Given this list of marker genes RAD51, POMT1, TCTN1, STAG1, CDC42, KIF7, SETBP1, SOX11, RFWD3, CDC45, NOTCH3, KMT2D, PTCH1, FGFR3, CEP290, SNX14, TGFBR2 (transforming growth factor beta receptor 2), PLG, MAB21L1, BCOR, VPS51, GTF2I, GPC3, SMG9, AP1S2, COL4A1, DYNC2H1, EVC2, SF3B2, WDR81, POMGNT1, RAPSN, EBP, NONO (non-POU domain containing octamer binding), B3GALNT2 (beta-1,3-N-acetylgalactosaminyltransferase 2), DDX3X, ARID1B, TSEN54, SKI, TXNDC15, TMEM94, NFKB2, CEP57, SMO, PTH1R, TRIP13, ZSWIM6, CRPPA, TCTN2, FKRP, TUBA1A, TMEM138, DPH2, BUB1, TBL1XR1, SMARCC2, ATP6V1A, TUBB, OPHN1, POLR1A, NPHP3, EVC, NUP88, FLVCR2, PIEZO2, KIF21A (kinesin family member 21A), HYLS1, DACT1, DYNC2I1, CC2D2A, GMPPB, RRAS2, GLI3, METTL27, MYOD1, FTO, GRIA3, SC5D, LONP1, GJB6, DNAJC30, COL3A1 (NCBI Gene Id 1281), TMEM107, DOK7, SH2B1, CSF1R, TBL2 (transducin beta like 2), WASHC5, TMEM270, STAT3, BUD23, B4GALT1, SEPSECS, FAR1, FKBP6, HRAS, PHGDH, PHEX, POLR3A, DPF2, PIGN, SMARCE1, NOVA2, CHD4, POR, MID1, MKS1, KCNH5, CSPP1, CTSK, KIAA0586, GTF2IRD1, NCF1, C2CD3, SLC30A7, FBN1, MLXIPL, TONSL, SLC18A3, OFD1, RNF113A, VRK1, PLAAT3 (phospholipase A and acyltransferase 3), ATP6V1E1, FKTN, TMEM237, BUB3 (BUB3 mitotic checkpoint protein), TMEM231, IFT80, H3-3A, MT-CYB, TAOK1, RNU4-2, GPC4, HMGA2, NOTCH2, DENND5A, PLCH1, KCNQ1, SPRED1, PPP1R12A, COG8, AFF3, MAF, CDKN1C, DKK1, SLC35A2, ATP6V0A2, GRM1, POLR3B, PIK3CA, SIK3, RXYLT1, MAGEL2 (MAGE family member L2), ERF, FANCI, NFIA, SLC39A14, ELN, MUSK, RFC2, BUB1B, VANGL1, DPH1, POMT2, SMARCD1, RPGRIP1L, DNMT3A, TMTC3, DHCR7, KRAS, LARGE1 (LARGE xylosyl- and glucuronyltransferase 1), DHDDS, EXOSC9, CHD7, POMK, SETD2, CPT2, TMEM67, B9D2, GTF2IRD2, GJB2, DAG1, LIMK1, ALG3, FUZ, KANSL1, SLC25A46, WDR35, TSEN15, NRAS, AGTPBP1, BICRA, WDR73, RECQL4, PPP1CB, BAZ1B, TGFBR1, B4GAT1, CEP120, CREBBP, FGFR2, PAX2, CWC27, FOXF1, EIF4H, TRPM3, PDHA1, PORCN (NCBI Gene Id 65017), KCNQ1OT1, TSEN34, MBTPS2, AHDC1, PEX11B, ASXL1, GTPBP2, LEMD3, DYNC2I2, CCDC22, LAMA1, SON, MAP3K7, USP9X (ubiquitin specific peptidase 9 X-linked), B9D1, DPYSL5, GNAQ, KDM6A, RPGRIP1, TBC1D24, SOX4, VPS35L, SMARCB1, PGAP2, SMARCA4, TMEM216, TCTN3, ARID2, EXOSC3, SEMA3E (NCBI Gene Id 9723), EP300, ATP6V1B2, IL11RA, PDGFRB, MTM1, FLNA, IGF2, ZEB2, SALL1, DOCK6, EXOSC8, MAN2B1, VPS37D (VPS37D subunit of ESCRT-I), HES7, ARMC9 (armadillo repeat containing 9), BLTP1, FGFR1, SMARCA2, STX1A, ARID1A, ESCO2, KIF5A, POGZ, ZIC1, PMM2, CLIP2 (CAP-Gly domain containing linker protein 2), POMGNT2, TSEN2, here is a description of the gene set: Human Gene Set: HP_CEREBELLAR_MALFORMATION Cerebellar malformation studied in species Homo sapiens